The following is a description of a gene set: studied in species Mus musculus Mouse Gene Set: REACTOME_ACTIVATION_OF_THE_AP_1_FAMILY_OF_TRANSCRIPTION_FACTORS Activation of the AP-1 family of transcription factors, and this is the list of marker genes: Mapk8, Mapk11 (NCBI Gene Id 19094), Mapk14, Atf2, Mapk10, Mapk1, Mapk3, Mapk9, Fos, Jun